The following is a description of a gene set: Human Gene Set: GOBP_TOR_SIGNALING The series of molecular signals mediated by TOR (Target of rapamycin) proteins, members of the phosphoinositide (PI) 3-kinase related kinase (PIKK) family that act as serine/threonine kinases in response to nutrient availability or growth factors. studied in species Homo sapiens, and this is the list of marker genes: RNF167, CTNS, FAM83D, GPR137C, GPR155, SMCR8, C9orf72, STAMBPL1, TBC1D7, AKT3, LAMTOR4, KPTN, FNIP1, WDR59, GSK3B, KICS2, FLCN, CUL3, MTM1, CASTOR1, UBE2W, PIM1, USP7, SH3BP4, NLK, PRKAA1, TNFAIP8L1 (NCBI Gene Id 126282), RFFL, ROS1, RRAGA, GPR137B (G protein-coupled receptor 137B), RPS6, LARS1, RPS6KB1, XBP1, ENDOG, SIK3, EIF4EBP1, RPS6KB2, RRAGB, RNF152, YWHAZ, RBX1, GAS6, SYK, CCDC88A, ARMH4, LAMTOR3, DEPTOR, TMEM127, NPRL2, LIPA, RHEB, CLEC16A, MIRLET7F1, LIN28A, EVA1A, UBE3A, SEH1L, PREX1, TSC1, PRKACA, SIRT1, DYRK3, GATA3, RPS6KA3, NPC1, RPTOR, EP300, PINK1, RPS6KA5, PIH1D1, LEP (leptin), CARD11, UBE2N, ITFG2 (integrin alpha FG-GAP repeat containing 2), LARP1, OTUD7B, PPDPF, GNA12, SRC, RICTOR, USP32, TBCK, DDIT4, MIOS, PDCD6, PKHD1, GSK3A, RRAGD, LAMTOR2, LAMTOR5, AKT1, CASTOR2, SZT2, MIR199A1 (NCBI Gene Id 406976), PREX2, RPS6KA6, YWHAG (NCBI Gene Id 96443), NPRL3, DGKQ, GOLPH3, SHQ1, MFSD8, MAT2A, MEAK7, DISC1, PIK3CA, CRYBA1, MINAR1, ZMPSTE24, PRR5, STK11, VHL, SLC38A9, EPM2A, MAPKAP1, GPR137, RPS6KA1, HIF1A, HDAC3, UBR2, BMAL1, SEC13, SRMS, PELI1, OGT, TBK1, GBA1, EIF4EBP2, ATXN3L, PRKAA2, MTOR, F7, PIP4P1, USP9X, AKT1S1, SAMTOR, FBXO9, ATM, LAMTOR1, DEPDC5, SYAP1 (NCBI Gene Id 94056), TIPRL, PRR5L, MAPK3, SESN1 (sestrin 1), SAR1B, PRMT1, HTR6, WAC, WDR24, F10, OTUB1, SAR1A, RPS6KA2, FNIP2, KLHL22, SPAAR, USP4, RHEBL1, MAPKAPK5 (NCBI Gene Id 8550), TTI1, ARAF, NCKAP1L, RRAGC, UBE2D1, GPAT3, CCL5, F3, TSC2, SESN2, PRKACB, ATXN3, UBR1, SESN3, RELN, RPS6KA4, MLST8, CSNK1A1, CASTOR3P, TREM2, OTUD5